The following is a description of a gene set: species: Homo sapiens Epistaxis, or nosebleed, refers to a hemorrhage localized in the nose. Human Gene Set: HP_EPISTAXIS Epistaxis, and this is the list of marker genes: HPS1, RARA (retinoic acid receptor alpha), TBXA2R, GP1BA, IRF2BP2, HLA-DPA1, F8, F2, APOLD1, SRC, SLC37A4, ETV6, GDF2, F13A1, BCOR, P2RY12, CACNA1D, FIP1L1, PLCG1, SLFN14, HPS5, BLOC1S3, STIM1, CDC42BPB, ATP8B1, PRF1, LMX1B, WAS, TBL1XR1, HLA-DRB1, PRKACG, RUNX1, CTLA4, NBEAL2, MCFD2, PRTN3, PML, TERC, FERMT3, F7, ZBTB16, SMAD4, F13B, GATA1, HPS6, MYH9, TPM4, NUMA1, RASA1, NPM1, VWF, F9, PRKAR1A, GALE, P4HA2, HMOX1, FGB (fibrinogen beta chain), ITGB3, CYP11B2, STXBP1, EPHB4, FYB1, HLA-DPB1, NABP1, CYP11B1, GP6, DTNBP1, CLCN2, WIPF1, GP9, STAT3, JAK2, ENG, PTPRJ, SERPINE1, IFNG, F5, GBA1, KCNJ5, MYD88, EPOR, FGG, FCGR2C, F11 (NCBI Gene Id 72031), BLOC1S5, GGCX, ACVRL1 (NCBI Gene Id 94), SBDS, ITGA2B (integrin subunit alpha 2b), GIMAP5, CEBPE, FGA (NCBI Gene Id 2243), ACTN1, HLA-B, LYST, PTPN22, TERT, RASGRP2, GFI1B, GP1BB, F10, STAT5B, LMAN1, HPS4, HPS3, GNE, PLAU